The following is a description of a gene set: Genes predicted to be targets of miRBase v22 microRNA hsa-miR-200c-3p in miRDB v6.0 with MirTarget v4 prediction scores > 80 (high confidence targets). from publication Chen Y, Wang X (PMID 31504780) species: Homo sapiens Human Gene Set: MIR200C_3P, and this is the list of marker genes: PPP1R10, RUSC2, ARID4B, MAP4K5, TCAIM (NCBI Gene Id 285343), ROCK2, TUBB, CLIC4, STRN, HS3ST1 (heparan sulfate-glucosamine 3-sulfotransferase 1), DENND1B, PKD1, GLI3, IMMP2L, TSSK1B, CSNK1G3, HIPK1, ATXN1 (ataxin 1), OTUD4, SERPINI1, STK4, ARL5A, CEP350 (centrosomal protein 350), LRRC8A, TAF12, OSTM1, PABIR3, POGLUT2, IKZF2, CNOT6 (NCBI Gene Id 60404), SULF1, FBXO33, PPP1R18, PPP1R9B, OSBPL11, FAT3, CASZ1, BLCAP, RTKN2, PDS5B, TRHDE, YWHAB, ZC3H4, PHTF2, GSTA4, RNF19A, CNTN1, CCNYL1, GABBR2, IGF2R, ANKRD40, RIC1, PGM2L1, PLPPR4 (NCBI Gene Id 9890), PKIA, ALDH1A1, C11orf87, GPATCH8, NR3C1, CDYL2, CLASP2 (NCBI Gene Id 440948), CAMSAP2, HOOK3, PPP2R5E, NCS1, SLC30A7, RAP1B, RND3, VEGFA, ENO4, HMBOX1, GNAQ, UBE2R2, MIEF1, BLTP3A, DPY19L3, MAPRE1, SDC2, SLC25A36, RDH10, LRP1B (LDL receptor related protein 1B), LEPR, SYNJ1, CRH, DDIT4L, GATA4, FOXN2, ITGA1, PTPN12, CERT1 (ceramide transporter 1), RECK, INTS8, KCNQ3, HYCC2, RANBP9, GTPBP10, TENT4B, EIF4E2, CASR, SBSPON, MSL2, CSMD3, AMFR, DZIP1 (DAZ interacting zinc finger protein 1), GJC1, EPS8, GPM6A, FRMD6, SLC39A14, CORO1C, DPH6, SEMA3F, DGKA, NRG1, DESI1 (NCBI Gene Id 91610), SPAG9, PCDH19, SLC1A2, TRIM33, A1CF, AGFG1, SUSD5, CDK17, DUSP1, GPR180, PAG1, PTAR1, ZNF326 (zinc finger protein 326), CDYL, SGCE, JAZF1, GTF3C4, TBX18, PPFIA1, CHN2, TLN1, SUZ12, RO60 (NCBI Gene Id 6738), CCDC177, KDR, REEP1, RANBP10, PRTG, SYVN1, CAB39, PCMTD1, CDH20, AFF3, AKAP7, MARCHF6, CLVS2 (clavesin 2), RAP2C, IGSF10, WASF3, MPDZ, BRWD3, ZDHHC21, DNAJB9, NAP1L5, MAP2, ZFPM2, IPO7 (NCBI Gene Id 10527), JAKMIP2, ZNF131, ERG, HS3ST3A1, FAM118B (NCBI Gene Id 79607), EXOG, MYZAP, USP6NL, SEC23A, PPHLN1, MSN, GAS2L3, KYNU, NOVA2, USP27X (NCBI Gene Id 389856), CUX1, PROK2, PMAIP1, ZEB2, FEZ2, ADIPOR2, SESN1, NANOS1, MBNL2, SYDE1, NR5A2, FIGNL2, PUM2, CYTH3, DNAJC3, ANK3, KCTD8, SLC4A7, PI4K2B (NCBI Gene Id 55300), SLC14A1, VAT1L, TMEM17, SNX16, RNF2, FNDC3B, PTPRZ1, PLXNC1, TBL1XR1, ZNF532, NCOA2, TSC22D1, FBXW7, XKR4, ZEB1, THAP2, ADAMTS3, EXD2, SLC6A1, CEP97, PICALM, SCN5A (NCBI Gene Id 652341), NTF3 (NCBI Gene Id 4908), SCN8A, PTHLH, DNA2, S100PBP, XKR8, NFIA, CYTH1, KRT80, FSCN1 (NCBI Gene Id 6624), HOOK1, JUN, LRP1, PPM1B, PPP4R2, B3GLCT, SMARCD1 (SWI/SNF related, matrix associated, actin dependent regulator of chromatin, subfamily d, member 1), GOLGA1, NOVA1, CNEP1R1 (NCBI Gene Id 255919), MCFD2, HDHD2, MEX3D, PIKFYVE, TOGARAM1, DLC1, PLPP3, LOX, TAP2, TMX4, ARL2BP, WIPF1, ARHGAP20, CEP41 (centrosomal protein 41), ZKSCAN8 (NCBI Gene Id 7745), TLN2, NUFIP2, RASSF8, RIMS2, ZFAND6, ARIH1, SCD, MYB, ZMAT3, MARCKS, CHRNA6, PPM1F, CLASP1, ATAD2B, SEMA6D, SGIP1, NEDD1, MAP3K1, COPS8, ANKRD44, JCAD, IER5, CEP85L, DCUN1D5, KCND2, BDP1, CNKSR3, TSC22D2, SERINC1, VLDLR, GXYLT1, KANK2, NOG, ZSWIM4, FLII, USP25, ELL2, SLC35E2B, SNRPB2, JKAMP, MIB1, DPY19L1, WWC3, MPRIP, CKAP4, NOTCH1, KIF14, ZNF217, PRKACB, PSAT1, POLK, QKI, TMOD3, PRDM16, ASAP1, HS2ST1, DNAJB5 (NCBI Gene Id 25822), UBE2W, WNT16, EIF2B5, BICC1, LIN7A, HAPSTR1, TIMP2, BAP1, DENND5B, RPS6KB1, RAB11FIP2, GLCCI1, MARF1, ETS1, CRKL, FERMT2, ERRFI1, MED13, TRAPPC8, PHACTR3, FLI1, TBC1D12, KLF4, FN1, FOXG1, NECTIN4, GARRE1, TMEFF2, SLK, PHF21B, PDIK1L, FIGN, ELK4, KLF6, DCBLD2, HSPA13, PPP1R9A, HNRNPD, TRMT9B, MOSMO, NRBP1, CHRM2, SLC35E2A, MAP4K3, RIPK2, CNOT9, PPM1E, SLC24A4, PITPNM3, ATL2, GOLGA7, CBL, ZBTB10, GPRASP2, CCNE2, KHDRBS1, NPM1, TBK1, GEM, ELOC (elongin C), SRI, PIM2, MBOAT2, SESN3, CCDC82, FSD1L, RGL1, ELAVL2, ERICH4, NTRK2, CTDSPL2, CRTAP, BCL11B, B3GNT2, TLCD5, DNMT3B, EGLN1, SIX1, STRADB, MGAT2, ADH1B (NCBI Gene Id 125), CPED1, KDM7A, SRGAP1, AP1S2, TFAP2A, RRP15, DGKH, INSM2, CECR2, RBSN, PCLAF, B4GAT1 (beta-1,4-glucuronyltransferase 1), CBX4, CLIP1, ZFTA, SCAMP1, MMD, HDAC9, RBFOX3, ZCCHC24, EDEM3, NUDT4, ATP5F1B, DACH1, ELK3, WASF1, RDX, HECTD2, CCNJ, DTNA, THAP1, FSTL1, VASH2, CHRDL1, MATR3, TOB1, OCLN, EVI5, MAP4K4, FARP1, LHFPL6, FAM227B, SCRT2, NPC1, HMGB3, ZFX, SLITRK1, ZC3H6, PTBP3, FOXF1, GPR158, SECISBP2L, TRIM23 (tripartite motif containing 23), SCAI, PRDM1, WDR82, WAPL, APOO, ZNF224, RAB21, MINDY2, VASH1, ULK2, PI4KB, DENND5A, NBR1 (NBR1 autophagy cargo receptor), ZNF711, RTF1, ELMOD2, YPEL2, SFXN1, RASA2, ARHGAP6, ESRRG, ATP11C, MAPK7, NCK2, PHEX, GIT2, PPP2R1B, FHL1, PTPN14, FAM8A1, DIXDC1, RBFOX2, ZBTB38, SLIT2, PTPN21, SOX2, CHSY1, SLF2, SLC35B4, PRKG1, YWHAG, RPS6KA3, TBCA, PIK3CA, CFL2, LBR, FBXO30, SLC6A11, PSIP1, BNC2, MBNL3, ZYG11B, NAB1, MTF2, HIPK3, MFAP5, PLCL1